The following is a description of a gene set: Mouse Gene Set: MIR_7667_3P from publication Chen Y, Wang X (PMID 31504780) species: Mus musculus Genes predicted to be targets of miRBase v22 microRNA mmu_miR_7667_3p in miRDB v6.0 with MirTarget v4 prediction scores > 80 (high confidence targets)., and this is the list of marker genes: Prdm6, Tnpo1, Ak5, Il4ra, Mtmr11, Tas1r3, Wtap, Clec14a, Zfp672, Srgap3, Ikzf2, Asap2, Gnrhr, Ccdc47, Elavl1, Hs6st1, Mgat3, Rfx3, Dnajc14, Rnf169, Abcc1, Zfp947, Trp53i11, Elk1, Kdm6b, Arfip2, Epn2, Gnao1, Wdr45b, Col6a5, Ap3s2, Rbfox3, Tfip11, Pfkfb2, Inpp5e, Dcaf8, Artn, Ocel1, Igf2, Sh3glb1, Tbc1d14, Fpr2, Car12, Rapgefl1